Given this list of marker genes MT-CO1, ALG12 (NCBI Gene Id 79087), MT-ND1 (NCBI Gene Id 4535), IFT56, MT-TF, MT-ND5, CHD3, MT-TW, IDH1, MT-ND4, MT-CO2, MT-CO3, MT-TL1, MT-TH, MT-TQ, MT-TS2, NARS1, MT-ND6, here is a description of the gene set: Widened cerebral subarachnoid space An increase in size of the anatomic space between the arachnoid membrane and pia mater in the region surrounding the cerebrum. studied in species Homo sapiens Human Gene Set: HP_WIDENED_CEREBRAL_SUBARACHNOID_SPACE